Given this list of marker genes Acta2, Umod, Mir125b-2, Pou3f3, Mir125b-1, Mir330, Ren1, here is a description of the gene set: species: Mus musculus The process whose specific outcome is the progression of the juxtaglomerular apparatus over time, from its formation to the mature structure. The juxtaglomerular apparatus is an anatomical structure that lies adjacent to the glomerulus and regulates kidney function. Mouse Gene Set: GOBP_JUXTAGLOMERULAR_APPARATUS_DEVELOPMENT